Given this list of marker genes HLA-DOB, SIDT1, SLC6A16, PNO1, MTMR1, PLAGL2, NASP, LCK, SYBU, CHMP7 (charged multivesicular body protein 7), SORL1, RGS14, FAM30A, P2RY10, WNT16, OAS2, HYI, ZSCAN32, NOL9 (nucleolar protein 9), TENT5C, DEFA4, RAF1, DIDO1, MTSS1, ZNF473, KIF21B, GIT2, LAT2, IRF8, TRIB2, CD34, PRODH, RFPL2 (NCBI Gene Id 10739), HOXB9, MEST, SHFL, CDC25B, CD72, DGKD, ZHX2, IGLL3P, INAVA, SPINK2, ARID5B, BCL2, HDDC2, C2orf42, PI4KB, VN1R1 (vomeronasal 1 receptor 1), GALNT3, THBS1, ZDHHC14, TRRAP, TRAPPC2, MAGEC1, PARM1, IGKC, NGDN, TMSB15B, ARL4A, KLF2, WEE1, BIK, KLHDC4, KIF13B, RUBCNL, TMEM8B, RBM14, RPS3A, CENPA, FCMR, ZNF394, PPP4R3B, PKIG, SIPA1L3, IGHM, MCF2L-AS1, HSPA1L, HLA-A, IFRD2, PTCH1, SNRNP200, SIK3, FOXJ2, DOLPP1, SEL1L3, MAP3K1, TROAP, BEGAIN, PIK3C2B, PERP, HOXB2, JAK1, ANKRD17, SINHCAF, RABGEF1, ATP6V1G1, HCP5, LAMC1, PSME3IP1, UGT2B15, SYNE1, IGHV5-78, ZNF81, FAM117A, JAM3, LTB, FBXO21, CHRNB4 (cholinergic receptor nicotinic beta 4 subunit), PHF1, SLC2A5, HCRTR2, CNOT8, PRDM14, TPX2, CCDC81, TCF7, C10orf95-AS1, FBXL7, EEF1D, FTSJ1, ACAD10, GLOD4, C11orf71, BCL11A, APOH, ZNF506, UBR7, ZNF586, ZNF22, SPTBN1, CIITA, C21orf91, RPL37, CRLF3, KCNE5, CTCF, CCR9, FMO1, IRF7, MON1B, ACKR2, PMS2P5, DUSP1, GOLIM4, RHOH, RUFY1, ITGAL, JOSD1, HHIPL2, LBH, SRRT, CHRNA9, TESK2, E4F1, PIP5K1B, ABCB7, RUBCN, PRRG3, CSGALNACT1, NCK2, TFF3, SPRR3, PARP1, MEFV, PRKCZ, GABPB1, ANKRD27, GTF3A, ADAM28, ZNF142, RPL6, S1PR1, UBE2J1, CTBP1, TRADD, TCL1A (TCL1 family AKT coactivator A), KCNC4, BUB1B, TSPYL2, INPP5A (inositol polyphosphate-5-phosphatase A), SLC44A4, BBS9, RAB28, KIF4A, TRAF3IP3, H2BC8, TIMP4, CYTH1, PNOC, TMEM268 (NCBI Gene Id 203197), SYNRG, TPM3, POLR1G, FAM193B, MYL2, ZDHHC8BP, here is a description of the gene set: from publication Jeffrey KL, Brummer T, Rolph MS, Liu SM, Callejas NA, Grumont RJ, Gillieron C, Mackay F, Grey S, Camps M, Rommel C, Gerondakis SD, Mackay CR (PMID 16474395) species: Homo sapiens Genes down-regulated in comparison of dendritic cells (DC) versus B cells. In the present study we used Affymetrix oligonucleotide microarrays to produce gene transcription profiles for the major leukocyte types in humans. This comprehensive dataset enabled us to not only establish which genes were expressed in each leukocyte type, but also which genes were expressed in each subset after activation. The used of a comprehensive dataset of gene profiles from all the major human leukocyte subsets enabled a novel and powerful means for identification of genes associated with single leukocyte subsets, or different immune paradigms. Human Gene Set: GSE3982_DC_VS_BCELL_DN